The following is a description of a gene set: electronically inferred by orthology from the curated human pathway Reactome Pathway: Metabolism of ingested SeMet, Sec, MeSec into H2Se This event has been computationally inferred from an event that has been demonstrated in another species.<p>The inference is based on the homology mapping from PANTHER. Briefly, reactions for which all involved PhysicalEntities (in input, output and catalyst) have a mapped orthologue/paralogue (for complexes at least 75% of components must have a mapping) are inferred to the other species. studied in species Mus musculus part of: Selenoamino acid metabolism, and this is the list of marker genes: Mat1a